The following is a description of a gene set: The directed movement of membrane-bounded vesicles from endosomes back to the trans-Golgi network where they are recycled for further rounds of transport. Mouse Gene Set: GOBP_RETROGRADE_TRANSPORT_ENDOSOME_TO_GOLGI species: Mus musculus, and this is the list of marker genes: Snx2, Pheta1, Lrrk2, Wipf3, Snx8, Arfrp1, Trappc10, Usp7, Rab7b, Rab14, Tbc1d10a, Golt1b, Rbsn, Ric1, Rab4b, Tbc1d10b, Arl8b, Washc2, Erc1, Dennd2a, Rab9b, Arfip1, Rufy1, Bet1l, Snx1, Tmem87a, Rab6b, Rnf126, Vps51, Stx5a, Ykt6, Magel2, Dennd5a, Atp9a, Golt1a, Plekha3, Tbc1d5, Sgsm2, Vps53, Washc1 (NCBI Gene Id 68767), Vti1a, Spag9, Vamp3 (NCBI Gene Id 320838), Ap5z1, Eipr1, Ap1s1, Tbc1d23, Gosr1, Bltp3b, Tbc1d17, Rab7, Vps50, Heatr5a, Rab29, Rab6a, Cln5, Tbc1d14, Ankfy1, Ehd3, Vps29, Snx12, Vps52, Pheta2, Trim27, Stx6, Vti1b, Snx3, Pikfyve, Tbc1d10c (NCBI Gene Id 74822), Rgp1, Evi5, Cltc, Snx32, Rcsd1, Snx6, Stx16, Gcc2, Ube2o, Prepl, Arl1, Snx5, Plekhj1 (pleckstrin homology domain containing, family J member 1), Tmem87b, Rhobtb3, Gbf1, Baiap3, Vps26b, Heatr5b, Rab9, Slc66a2, Dctn1, Gga1, Vps35, Vps54, Vps26a